The following is a description of a gene set: species: Mus musculus Genes negatively differentially expressed in cell type: CD4+ T cell upon treatment with cytokine: VEGF in mouse lymph nodes in vivo. Mouse Gene Set: CUI_T_CELL_CD4_VEGF_RESPONSE_DN from publication Cui A, Huang T, Li S, Ma A, Pérez JL, Sander C, Keskin DB, Wu CJ, Fraenkel E, Hacohen N (PMID 38057668) Cytokines mediate cell-cell communication in the immune system and represent important therapeutic targets. A myriad of studies have highlighted their central role in immune function, yet we lack a global view of the cellular responses of each immune cell type to each cytokine. To address this gap, the authors created the Immune Dictionary, a compendium of single-cell transcriptomic profiles of more than 17 immune cell types in response to each of 86 cytokines (>1,400 cytokine-cell type combinations) in mouse lymph nodes in vivo. A cytokine-centric view of the dictionary revealed that most cytokines induce highly cell-type-specific responses. For example, the inflammatory cytokine interleukin-1β induces distinct gene programmes in almost every cell type. A cell-type-centric view of the dictionary identified more than 66 cytokine-driven cellular polarization states across immune cell types, including previously uncharacterized states such as an interleukin-18-induced polyfunctional natural killer cell state., and this is the list of marker genes: Hspa1a, Jun, Junb, Hspa1b, Cd74